The following is a description of a gene set: Apoptosis Mouse Gene Set: WP_APOPTOSIS species: Mus musculus, and this is the list of marker genes: Irf7, Pik3r1, Tnfrsf1b, Tnfrsf10b (NCBI Gene Id 56871), Nfkbie, Apaf1, Bcl2, Dffb, Irf3, Irf1, Map3k1, Hells, Bax, Myc, Prf1, Map2k4, Casp3, Tnf, Casp8, Casp1, Dffa, Xiap, Casp9, Pmaip1, Nfkb1, Mcl1, Irf5, Bad, Trp53, Hrk, Trp63, Tnfsf10, Fasl, Rela, Mapk10, Igf1, Traf3 (NCBI Gene Id 22031), Bcl2l2, Trp73, Nfkbib, Bcl2l1, Birc2, Tnfrsf25, Diablo, Irf6, Bok, Jun (NCBI Gene Id 16476), Bid, Chuk, Fas, Igf1r, Traf2, Cflar, Traf1, Birc3, Gzmc, Lta, Ikbkg, Irf2, Birc5, Mdm2, Bcl2l11, Scaf11, Ripk1, Ikbkb, Cradd, Casp2, Casp6, Nfkbia (nuclear factor of kappa light polypeptide gene enhancer in B cells inhibitor, alpha), Bnip3l, Tnfrsf21, Casp7, Tradd, Tnfrsf1a, Igf2, Akt1, Irf4, Casp4